The following is a description of a gene set: Human Gene Set: REACTOME_EXTRACELLULAR_MATRIX_ORGANIZATION species: Homo sapiens Extracellular matrix organization, and this is the list of marker genes: DTNB, VWF, TNN, ADAMTS5, JAM2, LRP4, HTRA1, FBN2, PECAM1, PLEC, ADAMTS18, COL22A1, P3H2, ITGB4, COL6A1, FBLN1, CMA1, SDC2, GDF5, LAMA4, PCOLCE, DRP2 (NCBI Gene Id 1821), BMP2, MMP7, COL11A1, EMILIN1, SERPINE1, LTBP3, VCAM1, ADAMTS3, FGA, ADAM12, PHYKPL, CD44 (NCBI Gene Id 960), COL5A2, ACTC1, ACTA2, NID1, MMP20, CTSL, P4HB, SDC4, LAMA5, ELN, MMP24, SERPINH1, KLK7, ADAM15, IBSP, ITGB8, TLL2, ITGAL, SNTB2, MMP15, ADAM10, CAPN1, NCSTN, COL15A1, MFAP4, LOXL3, PCOLCE2, FBLN5, COL18A1, MATN4, ICAM2, ELANE, TPSAB1, SNTG2, FBN3, ITGA9, EMILIN3, NTN4, KLK2, COLGALT1, NID2, CTSD, SPP1, TNC, PPIB, KDR, MFAP5, COL20A1, MMP13, COL9A1, ITGA11, COL4A5, THBS1, MUSK, DMD, FGB, FGG, DDR1, ITGB1, ADAMTS16, ADAMTS14, PDGFA, F11R, LAMA3, CAPNS1, ITGA6, COL9A3, CD47, P3H3, MFAP3, MMP16, ADAM9 (NCBI Gene Id 8754), ITGAD, COL23A1, MMP8, COL1A1, ITGB3, COL6A6, ICAM1, DST, COL4A3, CAPN12, PLOD2, TGFB1 (NCBI Gene Id 7040), OPTC, COL24A1, MATN1, CAPN13, SNTA1, ITGA8, ITGAX, BCAN, SCUBE1, ITGB7, CD151, ICAM5, FBLN2, PLG, SGCD, LAMB3, CAPN2, LTBP1, COL19A1, COL14A1, COLGALT2, ITGA4, COL26A1, COL5A3, COL10A1, NCAM1, SPOCK3, MMP12, MMP14, COL11A2, EFEMP2, ACTN1, CAPN15, ITGB5, DSPP, CAPN6, COL6A5, ICAM4 (intercellular adhesion molecule 4 (Landsteiner-Wiener blood group)), COL7A1, ADAM8, FURIN, SH3PXD2A, SDC1, CTSB, PXDN, COL16A1, DTNA, MMP19, DCN, BMP10, ACTB, LAMC1, LAMB1, APP, ITGA10, ACTG2, TRAPPC4, P4HA3, ACTA1, COL6A2, TNXB, EFEMP1, SCUBE3, CASK, LAMC2, NRXN1 (neurexin 1), ACTG1, CAPN10, LOXL2, LTBP4, COL9A2, PLOD3, DAG1, DMP1, CTRB1 (chymotrypsinogen B1), CAPN5, COMP, ITGA2, KLKB1, NCAN, COL28A1, LAMA1, FN1, COL1A2, ADAMTS4, BGN, SGCZ, LOX, FGF2, BMP7, HAPLN1, TMPRSS6, CDH1, CASP3, ITGAE, SGCG, TIMP1, CTSK, ITGA7, COL4A6, CAPN8, ADAMTS8, ADAM19, TIMP2, COL8A2, CAPN7, COL17A1, ADAMTS9, PLOD1, MMP10 (matrix metallopeptidase 10), A2M, MFAP2, BMP1, ITGA5, MMP11, ACAN, UTRN, COL25A1, TGFB2, CEACAM1, LAMC3, CAPN11, MATN3, CEACAM8, P4HA2, LOXL1, COL27A1, DDR2, CRTAP, COL6A3, JAM3, CAPN9, BMP4 (bone morphogenetic protein 4), TGFB3, HSPG2, PSEN1, LOXL4, EMILIN2, MADCAM1, MMP2, LTBP2, PTPRS, PRSS2, CEACAM6, SSPN, SDC3, BSG, ITGA1, COL4A1, ASPN, ITGB2, SPARC, COL4A4, TNR, VTN, COL4A2, ITGB6, ICAM3, COL3A1, SGCA, TLL1, ITGA3, PDGFB, LAMA2, CAST, CTRB2, SGCE, COL12A1, CAPN14, PRKCA, AGRN, CAPN3 (NCBI Gene Id 825), ITGA2B, COL8A1, VCAN, SGCB, COL13A1, CTSV, MMP25, MMP17, CAPNS2, CTSS, P3H1, COL21A1, MMP9, P4HA1, COL2A1, ADAMTS1, ITGAM, FBN1, ADAM17, COL5A1, ITGAV, SNTB1, MMP3 (matrix metallopeptidase 3), TTR, PRSS1, MMP1, ADAMTS2, FMOD, LAMB2, LUM, CTSG